Given this list of marker genes MMP24, MYBPC2, FKBP4, TLCD5, STUB1, RPIA, HSPA8, YWHAB (NCBI Gene Id 7529), NRGN, GRB7, DHCR7, JAK2, TFAP2A, SCARB1, HELZ, DOCK3, ERBB2, CDH1, UST, FAAP20 (FA core complex associated protein 20), MIEN1, UBE2L3, SLF1, VPS37C, here is a description of the gene set: Invasive ductal carcinomas (IDCs) and invasive lobular carcinomas (ILCs) are the two major pathological types of breast cancer. Epidemiological and histoclinical data suggest biological differences, but little is known about the molecular alterations involved in ILCs. We undertook a comparative large-scale study by both array-compared genomic hybridization and cDNA microarray of a set of 50 breast tumors (21 classic ILCs and 29 IDCs) selected on homogeneous histoclinical criteria. Results were validated on independent tumor sets, as well as by quantitative RT-PCR. ILCs and IDCs presented differences at both the genomic and expression levels with ILCs being less rearranged and heterogeneous than IDCs. Supervised analysis defined a 75-BACs signature discriminating accurately ILCs from IDCs. Expression profiles identified two subgroups of ILCs: typical ILCs ( approximately 50%), which were homogeneous and displayed a normal-like molecular pattern, and atypical ILCs, more heterogeneous with features intermediate between ILCs and IDCs. Supervised analysis identified a 75-gene expression signature that discriminated ILCs from IDCs, with many genes involved in cell adhesion, motility, apoptosis, protein folding, extracellular matrix and protein phosphorylation. Although ILCs and IDCs share common alterations, our data show that ILCs and IDCs could be distinguished on the basis of their genomic and expression profiles suggesting that they evolve along distinct genetic pathways. Genes up-regulated in the invasive ductal carcinoma (IDC) compared to the invasive lobular carcinoma (ILC), the two major pathological types of breast cancer. from publication Bertucci F, Orsetti B, Nègre V, Finetti P, Rougé C, Ahomadegbe JC, Bibeau F, Mathieu MC, Treilleux I, Jacquemier J, Ursule L, Martinec A, Wang Q, Bénard J, Puisieux A, Birnbaum D, Theillet C (PMID 18490921) Human Gene Set: BERTUCCI_INVASIVE_CARCINOMA_DUCTAL_VS_LOBULAR_UP studied in species Homo sapiens